The following is a description of a gene set: Human Gene Set: DARWICHE_PAPILLOMA_RISK_HIGH_DN studied in species Mus musculus Genes down-regulated during skin tumor progression from normal skin to high risk papilloma. Chemical induction of squamous tumors in the mouse skin induces multiple benign papillomas: high-frequency terminally benign low-risk papillomas and low-frequency high-risk papillomas, the putative precursor lesions to squamous cell carcinoma (SCC). We have compared the gene expression profile of twenty different early low- and high-risk papillomas with normal skin and SCC. Unsupervised clustering of 514 differentially expressed genes (P<0.001) showed that 9/10 high-risk papillomas clustered with SCC, while 1/10 clustered with low-risk papillomas, and this correlated with keratin markers of tumor progression. Prediction analysis for microarrays (PAM) identified genes that distinguished the two papilloma classes, and a majority of these had a similar expression pattern in both high-risk papillomas and SCC. Additional classifier algorithms generated a gene list that correctly classified unknown benign tumors as low- or high-risk concordant with promotion protocol and keratin profiling. Reduced expression of immune function genes characterized the high-risk papillomas and SCC. Immunohistochemistry confirmed reduced T-cell number in high-risk papillomas, suggesting that reduced adaptive immunity defines papillomas that progress to SCC. These results demonstrate that murine premalignant lesions can be segregated into subgroups by gene expression patterns that correlate with risk for malignant conversion, and suggest a paradigm for generating diagnostic biomarkers for human premalignant lesions with unknown individual risk for malignant conversion. from publication Darwiche N, Ryscavage A, Perez-Lorenzo R, Wright L, Bae DS, Hennings H, Yuspa SH, Glick AB (PMID 17525749), and this is the list of marker genes: BRSK2, ANP32A, MED17, LYZ, TMEM144, LYAR, DIP2A, BAG6, NUF2, GNAO1, CA3, POLR1HASP, APOE, DENR, GBA1, MAN2A2, PYGO2, SPAG5, MYCN, CCL27, ARL2, ABHD14B, PKHD1, ACTG2, ACTL6B, FAM3A, GID8, YWHAB, CP, NIT1, CDC42EP2, CALM2, OGFOD2, GABARAPL2, GTF2E2, AFF3 (NCBI Gene Id 3899), ARMC9, PPP1R27, RBM12, SLC39A13, TRPC6, CPA5, KRT2, SPATA31D1, BAIAP2, DYNLT2B, COL20A1, C16orf90, TSC22D4, IGHG1, DCTN1, TYRO3, SLC35B1 (solute carrier family 35 member B1), TNP2, ANKEF1, RTRAF (RNA transcription, translation and transport factor), PAQR7, SRSF1, RNF19A, FAM178B, PDXDC1, SRF, LHX3, SIGLEC5, SAR1A, SMU1, CTSV, CHST11, MAP1LC3A, IFT20, FBRSL1, C11orf58, IL17A, MAP2K5, KRTAP6-1, OVOL2, HMBOX1, TRBV4-1, INAVA (innate immunity activator), CALCOCO1, SCN1B, ITPR1, PABPC4, ARAP1, MEF2C, RSPO1, TTLL11, BRF1, GSTZ1, BCL2A1, SPC24, SPP1, CHP1, TCP1, KRTAP5-2, C14orf119, PVT1, KCNU1, MSI1, COQ8A, ARHGAP4, QPRT, TLCD3B, NBN, SOX5, ACTA2 (NCBI Gene Id 59), GRIP1 (NCBI Gene Id 23426), PACSIN2, FAM217A, TREM2, PEPD, PLET1, LRRC58 (leucine rich repeat containing 58), POLI, TPM3, CITED2, CCNI, CHCHD5, STRAP, LTBP4, CX3CR1, PTPRJ-AS1, APOD, SOD3, PLAC8, SOD1, BHLHE22, RTN4R, PLA2G10, ACSBG1, CFAP144, UBE4B (ubiquitination factor E4B), ASNS, PATJ, ACAD9, AMBRA1, PEX16, CENPC, SMIM11, TEX48, TEKTIP1, CCT6B, EBF2, PHF2, IRAK1, AKIRIN2, SWAP70, FAM186A, ATP6V0D1, DGUOK, CLEC3B, YTHDF2, LMOD2, WDR70, ACTA1, ZNF787, TCTE1, TSSK6, CAPN2, RPAIN (NCBI Gene Id 84268), APP, GADD45GIP1, MYO1A, MEOX2, GTF2I, BEST1, TUBA8, PDP2, MAPK8IP3, RNF26, LGMN, NPTXR, CDS1 (NCBI Gene Id 1040), UCK2, PUS10, TTC9, LGALS2, MRPL19, DOK4, ZNF830, EIF5A, RNF181, OTUD1